Given this list of marker genes Coro1c, Micall2, Tmcc1, Dnm2, Sh3gl2, Cibar1, Opa1, here is a description of the gene set: Mouse Gene Set: GOBP_MEMBRANE_TUBULATION studied in species Mus musculus A membrane organization process resulting in the formation of a tubular projection. This may face inwardly (as in tubular membrane invaginations) or outwardly (as in endosomal tubules).